Given this list of marker genes NPR2, GATA6, NOTCH1, EPHA8, LHCGR, INHBA, EFNA5, POR, INHBB, PAX8, ITGA3 (integrin subunit alpha 3), TGFBR3, CCNA2, NSMF, SRD5A1 (NCBI Gene Id 6715), EDN1, EDNRA, GCLM, GHSR, GCLC, SCX, SRD5A2, GATA1, WT1, FSHR, ALAS1, SLC5A5, TOP1, here is a description of the gene set: Any process that results in a change in state or activity of a cell or an organism (in terms of movement, secretion, enzyme production, gene expression, etc.) as a result of a gonadotropin stimulus. Human Gene Set: GOBP_RESPONSE_TO_GONADOTROPIN studied in species Homo sapiens